Given this list of marker genes RUNX1, NFATC2, TNFRSF18 (TNF receptor superfamily member 18), IL2RA, FOXP3, IFNG, CR1, CTLA4, CBFB, IL2, here is a description of the gene set: The complex of CBFB and RUNX1 (AML1) controls transcription of the FOXP3 gene. FOXP3 is a transcription factor that acts as a key regulator of development and function of regulatory T lymphocytes (Tregs). Tregs are CD25+CD4+ T lymphocytes involved in suppression of aberrant immune responses seen in autoimmune diseases and allergies. FOXP3 can bind to RUNX1 and control transcriptional activity of the RUNX1:CBFB complex. RUNX1 stimulates transcription of IL2 and IFNG1 (IFN-gamma), and the expression of these two genes is repressed upon binding of FOXP3 to RUNX1. The complex of FOXP3 and RUNX1, on the other hand, stimulates transcription of cell surface markers of Tregs, such as CD25, CTLA-4 and GITR. In the absence of FOXP3, RUNX1 represses transcription of these genes.<br>The RUNX1:CBFB complex directly stimulates transcription of the CR1 gene, encoding Complement receptor type 1 (CD35). Expression of CR1 on the surface of activated T cells contributes to generation of Tregs. Reactome Pathway: RUNX1 and FOXP3 control the development of regulatory T lymphocytes (Tregs) part of: Transcriptional regulation by RUNX1 species: Homo sapiens